Given this list of marker genes SMYD5, LBH, FUT10, CDK2AP2, ING2, ZBTB16, NAP1L2, TGFB2, PRDM15, SFRP2, FUT9 (fucosyltransferase 9), HOXB4, CDKN2A, GNL3, MLLT3, BMI1 (BMI1 proto-oncogene, polycomb ring finger), VANGL2, ESRRB, NDUFS6, ETV5, SOX17 (SRY-box transcription factor 17), CUL3, EXT1, MIR145, WNT7A, TDRD12, NOTCH1, PAFAH1B1, FZD7, WWTR1, THOC2, NCOA3, WNT3A, EVI2B, MYB, YME1L1, ZFP36L2, here is a description of the gene set: species: Homo sapiens The self-renewing division of a stem cell. A stem cell is an undifferentiated cell, in the embryo or adult, that can undergo unlimited division and give rise to one or several different cell types. Human Gene Set: GOBP_STEM_CELL_DIVISION